The following is a description of a gene set: Human Gene Set: GOMF_SPHINGOSINE_N_ACYLTRANSFERASE_ACTIVITY Catalysis of the reaction: acyl-CoA + sphingosine = CoA + N-acylsphingosine. species: Homo sapiens, and this is the list of marker genes: CERS4, CERS1, CERS3, CERS6, CERS5, TLCD3B, CERS2